The following is a description of a gene set: A complex and coordinated series of cellular movements that occurs at the end of cleavage during embryonic development of most animals. The details of gastrulation vary from species to species, but usually result in the formation of the three primary germ layers, ectoderm, mesoderm and endoderm. Human Gene Set: GOBP_GASTRULATION species: Homo sapiens, and this is the list of marker genes: NOG, FOXC2, HNF4A, DVL2, COL11A1, ITGA2, PAX2, LDB1, RNF2, ITGA4, NF2, TBX6, COL12A1, MIXL1, GPI, CUL3, SOX7, SMAD3, WNT3, DUSP1, ETS2, TAF10, APLN, GATA6, COL5A2, OSR1, COL4A2, WNT11, HNF1B, PRKAR1A, FZD7, NCKAP1, ITGA5, KDM6B, KLF4, SIX2, TXNRD1, WLS, ETV2, POFUT2, IL1RN, COL6A1, ITGB3, FGFR1, MEGF8, EXT2, LEO1, ITGA3, MYADM, WNT5A, MBP, TP53, RBM14, MSGN1, MIR1-1, EOMES, ENSG00000285205, LAMB1, TWSG1, FGF8 (fibroblast growth factor 8), LAMA3, EPHA2, WNK1, CRB2, OTX2, LEF1, SNAI1, MESP1, WNT5B, EXOC4, RTF1, SOX2, MYH9, CTR9 (NCBI Gene Id 9646), MIR200C, APLNR, MAP2K1, FGFR2, KIF16B, INHBA, AMOT, MMP15, NANOG, FOXA2, PAF1, CFC1B, GRB2, NR4A3, MAP2K5, DKK1, MIR150, COL5A1, FOXF1, PRKACA, AXIN1, APELA, AHDC1, SFRP2, ITGB4, IL10, GDF3, HAND1, CER1, TAL1, DVL1, FOXC1 (NCBI Gene Id 3666), BMP7, SETD2, SUPT20H, DUSP2, SCX, APOA1, ITGA8, WNT3A, FN1, SRF, MKKS, RACK1, POU5F1, LMBRD1, EYA2, ADIPOQ, FRS2, MMP8, ATOH8, POGLUT1 (NCBI Gene Id 56983), PLPP3, ARMC5, TASOR, COL8A1, CDC73 (NCBI Gene Id 79577), EXT1, WNT8B, BRD3, DUSP5, TGIF2, GPC3, LRP5 (NCBI Gene Id 8058), MMP2, TBX20, CFC1, ITGAV, RIC8A, SYF2, HMGA2, ELF5, HSBP1, LBX2, BMPR2, TBXT, ACVR1, GSC, MACROH2A1, ACVR2B, ARFRP1, SMAD1, ITGA7, VTN, TLX2, NAT8B, VANGL2, TGIF1, GJA1, MIR221, ITGB1, TBX19, HIRA, LHX1, SOX17, MMP9, TENM4, NR0B1, NODAL, BMP4, PRICKLE1, UGDH, MAPK7 (mitogen-activated protein kinase 7), SMAD4, LAMB3, MMP14, MIR145, HOXA11, EYA1 (NCBI Gene Id 2138), ITGB2, EPB41L5, MESP2, SMAD2, NPHP3, ITGB5, ACVR2A, DLD, SFRP1, CTNNB1, DUSP4, BMPR1A, ZBTB17, TGFBR2, TRIM15, COL7A1, ZIC3